The following is a description of a gene set: studied in species Mus musculus Mouse Gene Set: REACTOME_REGULATION_OF_CYTOSKELETAL_REMODELING_AND_CELL_SPREADING_BY_IPP_COMPLEX_COMPONENTS Regulation of cytoskeletal remodeling and cell spreading by IPP complex components, and this is the list of marker genes: Pxn, Parva, Actn1, Parvb, Rsu1, Arhgef6, Tesk1 (testis specific protein kinase 1), Lims1